The following is a description of a gene set: electronically inferred by orthology from the curated human pathway part of: Metabolism of steroids species: Mus musculus This event has been computationally inferred from an event that has been demonstrated in another species.<p>The inference is based on the homology mapping from PANTHER. Briefly, reactions for which all involved PhysicalEntities (in input, output and catalyst) have a mapped orthologue/paralogue (for complexes at least 75% of components must have a mapping) are inferred to the other species. Reactome Pathway: Regulation of cholesterol biosynthesis by SREBP (SREBF), and this is the list of marker genes: Ran, Srebf2, Kpnb1